The following is a description of a gene set: species: Homo sapiens In innate immune responses, activation of Toll-like receptors (TLRs) triggers direct antimicrobial activity against intracellular bacteria, which in murine, but not human, monocytes and macrophages is mediated principally by nitric oxide. We report here that TLR activation of human macrophages up-regulated expression of the vitamin D receptor and the vitamin D-1-hydroxylase genes, leading to induction of the antimicrobial peptide cathelicidin and killing of intracellular Mycobacterium tuberculosis. We also observed that sera from African-American individuals, known to have increased susceptibility to tuberculosis, had low 25-hydroxyvitamin D and were inefficient in supporting cathelicidin messenger RNA induction. These data support a link between TLRs and vitamin D-mediated innate immunity and suggest that differences in ability of human populations to produce vitamin D may contribute to susceptibility to microbial infection. Genes down-regulated in monocytes (6h): untreated versus M. tuberculosis 19 kDa lipopeptide. Human Gene Set: GSE8921_UNSTIM_VS_TLR1_2_STIM_MONOCYTE_6H_DN from publication Liu PT, Stenger S, Li H, Wenzel L, Tan BH, Krutzik SR, Ochoa MT, Schauber J, Wu K, Meinken C, Kamen DL, Wagner M, Bals R, Steinmeyer A, Zügel U, Gallo RL, Eisenberg D, Hewison M, Hollis BW, Adams JS, Bloom BR, Modlin RL (PMID 16497887), and this is the list of marker genes: UBE2L3, RAD51C, CHSY1, KLRG1, DLAT, SMIM3, VAMP5, IRAK1BP1, B3GNTL1, IL12RB1, SKA1, NSD2, ARNT2, LAMC2, RTCA, DEK, PADI2, RRM1, TAPBP, VGLL3, EME1, SBSPON, SCAMP2, S100A14, BCL6, IL13RA1, BCKDK, KLRC1, RBBP8, ZCCHC17, HELLS, SORL1, SMAD3, NABP1, AKAP14, DPAGT1, IL18R1, MAGOHB, PGLYRP2, RBMS2, GLRX, GCH1, ILDR1, SERPINA12, EIF2AK3, GRP, TKTL1, CENPH, PTPN13, COASY, GAS2L1, FAM110D, ADAM8, RAB5A, DHX8, BHMT2, CDH2, CNTN2, DLGAP5, CDKN1A, SKA3, PNP, IFNG, SOX3, FBXW4, ITGB7, MMP14, LANCL3, CRIPTO, MCM3, PLAAT3, SLC2A12, SELENOH, DBI, CYLD, GPR68, NAB1, SLC25A19, RASGEF1A, PLK3, KNSTRN, COL4A4, MACIR, ABCB1, CD160, CHRNE (NCBI Gene Id 83405), RNLS, LRRN4, SGO2, ADM, CHURC1, RAD51AP1, GNPTG, NANS, KIAA1958, GINS4, FAM111A, METTL24, CDK2AP1, TK1, GCG, FAM72A, PLCD1, TMA7, NUF2, STMN2, PAX7, ENDOD1, WRN, DOC2A, PGGHG, APLP1 (amyloid beta precursor like protein 1), RIGI (NCBI Gene Id 23586), RPA3, IGSF9B, CCP110, SMCO1, KCNK6, TNK2, CDC42EP3, TMBIM1, B4GALT5, CEBPZOS, CCR5, RBM47, GNPDA1, MFSD10, TDRD7, MASTL, CEMIP2, EBI3, UAP1L1, PEDS1, CCDC34, FGR, TRPM4, PPM1J (protein phosphatase, Mg2+/Mn2+ dependent 1J), CD6, PARP9 (poly(ADP-ribose) polymerase family member 9), CACNB4, CFB, MICU2, N4BP3, UBE2V1 (NCBI Gene Id 7335), C15orf48, ANAPC15, PDCD1, PAG1, BPIFA1, CARD10, RBL1, ATP5MK, KPNA2, TMIGD1, GGT1, NXN, ACSL5, HDLBP, KIFAP3, INIP, DIAPH3, RNF135, ENKD1, OXCT2, HMMR, CEP126, KIAA0753, PRC1, MYBPC2, RP1, CROCC, MAPRE2, NPNT, CDK5, CXCL10, C19orf25, ZNF679 (zinc finger protein 679), BUB1, MAP7D1, SMTNL1, SPATA2, RAB20, ACOXL, CEP170B, C8G, PRELID3B, ORAI3, MOGS, TBX21, SLC4A11, TBKBP1, CTNNA1, ACOT11, GNA15, EXOSC9, ABHD16A, AURKAIP1 (aurora kinase A interacting protein 1), RNF152, MLKL, CKS2